The following is a description of a gene set: Any process that results in a change in state or activity of a cell or an organism (in terms of movement, secretion, enzyme production, gene expression, etc.) as a result of a nicotine stimulus. species: Mus musculus Mouse Gene Set: GOBP_RESPONSE_TO_NICOTINE, and this is the list of marker genes: Chrna7, Ppara, Agtr1b, Nkx6-1, Rela, Chrna4, Ppp1r9b, Kcnk1, Chrna2, Chrna5, Slc7a11, Grm2, Edn1, Tnf, Mapk1, Th, Htr2c, Drd2, Gnat3, Tacr1, Chrnb3, Chrnb2, Gpx1, Penk, Igf2, Cnr1, Oprd1, Bad, Hmox1, Mmp2, Kcnj11, Gabbr1, Lypd1, Abat, Chrna6, Avp (arginine vasopressin), B2m, Casp3, mt-Nd6, mt-Nd4, Bcl2, Chrna3, Nfkb1, Pdx1, Slc6a3, Ppp1r1b (NCBI Gene Id 217160), Homer1, Atp1a2, Prss2, Chrnb1, Dhfr, Star, Il13, Chrnb4 (NCBI Gene Id 235389), Ntrk1 (NCBI Gene Id 97088), Fosb, Chrna1